Given this list of marker genes RPL5, PDIA3, BAG4, GDF15, TCF3, CD59 (CD59 molecule (CD59 blood group)), GADD45A, SLC39A7, PPP1CA, ANKRD1, CKMT2, ENG, SERPINH1, ZBTB7A, DUT, CDC34, FLOT2, TRIM58, SRGN, CTSB, CTSS, CCNH, RELA, C4BPA, HNRNPA1, TUBA4A, IL10RB, PLXNA1, CD68, SELENOP, TPT1, PKIA, UNG, TGFBR3, PTP4A3, RPL7A, AEBP1, DNAJA1, ATP6AP1, MPV17, CRYAB (NCBI Gene Id 1410), CFD, EID1, TSPAN4 (NCBI Gene Id 7106), MCAM, OAZ2, COMMD6, RCC1, UBE2J1, TAP1, HCFC1R1, CCNA2, PRKCSH (NCBI Gene Id 5589), CTNNB1, DNAJB1, PTGER4, PFDN5, ATP6V1C2, RAB36, PSMC4, RPL31, HMOX1, RPL21, CUX1, COX6C, CCND1, here is a description of the gene set: studied in species Homo sapiens Genes up-regulated in response to hydrogen peroxide in CS-B cells (Cockayne syndrome fibroblast, CS) expressing ERCC6 off a plasmid vector. from publication Kyng KJ, May A, Brosh RM Jr, Cheng WH, Chen C, Becker KG, Bohr VA (PMID 12606941) Cockayne syndrome (CS) is a human hereditary disease belonging to the group of segmental progerias, and the clinical phenotype is characterized by postnatal growth failure, neurological dysfunction, cachetic dwarfism, photosensitivity, sensorineural hearing loss, and retinal degradation. CS-B cells are defective in transcription-coupled DNA repair, base excision repair, transcription, and chromatin structural organization. Using array analysis, we have examined the expression profile in CS complementation group B (CS-B) fibroblasts after exposure to oxidative stress (H2O2) before and after complete complementation with the CSB gene. The following isogenic cell lines were compared: CS-B cells (CS-B null), CS-B cells complemented with wild-type CSB (CS-B wt), and a stably transformed cell line with a point mutation in the ATPase domain of CSB (CS-B ATPase mutant). In the wt rescued cells, we detected significant induction (two-fold) of genes out of the 6912 analysed. The patterns suggested an induction or upregulation of genes involved in several DNA metabolic processes including DNA repair, transcription, and signal transduction. In both CS-B mutant cell lines, we found a general deficiency in transcription after oxidative stress, suggesting that the CSB protein influenced the regulation of transcription of certain genes. Of the genes, 122 were differentially regulated by more than two-fold. Evidently, the ATPase function of CSB is biologically important as the deficiencies seen in the ATPase mutant cells are very similar to those observed in the CS-B-null cells. Some major defects are in the transcription of genes involved in DNA repair, signal transduction, and ribosomal functions. Human Gene Set: KYNG_RESPONSE_TO_H2O2